The following is a description of a gene set: Human Gene Set: GOMF_NAADP_SENSITIVE_CALCIUM_RELEASE_CHANNEL_ACTIVITY Enables the transmembrane transfer of a calcium ion by a channel that opens when nicotinic acid adenine dinucleotide phosphate (NAADP) has been bound by the channel complex or one of its constituent parts. studied in species Homo sapiens, and this is the list of marker genes: MCOLN1, TPCN1, MCOLN3, MCOLN2, TPCN2